The following is a description of a gene set: Mouse Gene Set: GOBP_PROTEIN_LIPOYLATION studied in species Mus musculus The lipoylation of peptidyl-lysine to form peptidyl-N6-lipoyl-L-lysine., and this is the list of marker genes: Lias, Gcsh, Lipt2, Ndufab1-ps, Ndufab1, Lipt1, Bola3 (bolA family member 3)